The following is a description of a gene set: Mouse Gene Set: CUI_T_CELL_CD4_IL18_RESPONSE_DN from publication Cui A, Huang T, Li S, Ma A, Pérez JL, Sander C, Keskin DB, Wu CJ, Fraenkel E, Hacohen N (PMID 38057668) species: Mus musculus Cytokines mediate cell-cell communication in the immune system and represent important therapeutic targets. A myriad of studies have highlighted their central role in immune function, yet we lack a global view of the cellular responses of each immune cell type to each cytokine. To address this gap, the authors created the Immune Dictionary, a compendium of single-cell transcriptomic profiles of more than 17 immune cell types in response to each of 86 cytokines (>1,400 cytokine-cell type combinations) in mouse lymph nodes in vivo. A cytokine-centric view of the dictionary revealed that most cytokines induce highly cell-type-specific responses. For example, the inflammatory cytokine interleukin-1β induces distinct gene programmes in almost every cell type. A cell-type-centric view of the dictionary identified more than 66 cytokine-driven cellular polarization states across immune cell types, including previously uncharacterized states such as an interleukin-18-induced polyfunctional natural killer cell state. Genes negatively differentially expressed in cell type: CD4+ T cell upon treatment with cytokine: IL-18 in mouse lymph nodes in vivo., and this is the list of marker genes: Tsc22d3, Ets1, Klf6, Hspa1a, Klf2, Crip1, Mxd4, Zfp36l2